Given this list of marker genes TBX1, TMEM270, EIF4H, VPS37D, FZD4, COL4A1, CLIP2, MLXIPL, GP1BB, UFD1, GTF2IRD2, GTF2IRD1, ANTXR1, LRP5, DNAJC30, RREB1, BUD23, ARVCF, NCF1, SEC24C, NDP, MT-ATP6, TBL2, RFC2, FKBP6, METTL27, HIRA, ELN, BAZ1B, GTF2I, LIMK1, STX1A, COMT, JMJD1C, here is a description of the gene set: Retinal arteriolar tortuosity Human Gene Set: HP_RETINAL_ARTERIOLAR_TORTUOSITY studied in species Homo sapiens The presence of an increased number of twists and turns of the retinal arterioles.